Given this list of marker genes PRKACB, SOD1 (superoxide dismutase 1), MAOA, TYR, PPP2CB, PRKACG (NCBI Gene Id 5568), TH, PPP2CA, COMT, DDC, MAOB, PRKACA, NQO1, here is a description of the gene set: Dopamine metabolism Human Gene Set: WP_DOPAMINE_METABOLISM studied in species Homo sapiens